Given this list of marker genes MAVS, SRPRB, WASH3P, ANKRD6, ACSL4, VPS13C, ANGPT1, PIK3R1, RBSN, MICALL2, RAC1, RILP, NOS2, CLOCK, CNIH4, ARCN1, TESC, TRMT10B (NCBI Gene Id 158234), IFT122, AP5Z1, LYPLA1, MTX1, EIF4ENIF1, VPS35L, VAMP8, FOXO1 (forkhead box O1), CRH, WHRN, TNF, DENND1B, AP3M1, SH3TC2 (NCBI Gene Id 79628), EI24, VPS45, CAPN10, AP3D1, TRH, TERT, RAMP3, APBA1, TRAM2, SSR3, RHOD, GHRL, CRY2, NUTF2, SCRIB, ACD, SNX33, ACAP1, ZFAND6, SYNE3, MYO18A, ZDHHC9, SYTL5, PAN3, PPM1F, PLCB1, CD74, CD33, MYO5A, SNX14, HAX1, NUP133, NAPA, MTNR1B, ENY2, NECTIN3, RBM4, VPS54, GOLGA7, AP1G1, CHMP2B, RTP1, KCNQ3, JAK2, SYNDIG1, RAB20, MIEF1, MIR130B, HSPA1L, ARL4C, DNM1L, FGF9, XPOT, STXBP3, GORASP1, BBC3, RABEP2, PLEK, LRRC32, COPB1, IL1A, MICALL1, SSR1, NUP153, GOLGA7B, SDAD1, HSPA8, ARL11, IFT56, AP2B1, STX7, SYBU, EPHA5, RAB3B, NUP62CL, HOOK3, STRADB, COG7, DNAJC1, NOMO3, UEVLD, ARL4D, ATP1B1, SIRT7, SCAMP1, CHML, ZDHHC11B, UNC119, WWP2, REP15, PFKL, MAIP1, PPP1R10, PLK3, TUNAR, ADAM9, DUOXA2, SLC1A1, TTN, HOOK1, RANBP17, EXOC6, RBP4, PARD3, CTSD, F2, SRP54 (NCBI Gene Id 6729), ARL8A, ACTN4, NR0B2, AP1S1 (NCBI Gene Id 574017), KDELR1, TOMM34, SNX5, AKAP5, PGAP1, RBM22, PLK1, ELMOD3, RAB21, GIP, IFT27, TMCO6 (NCBI Gene Id 55374), PPARG, STX19, DMAP1, MIR199A1, TMCO1, AP1M1, ZDHHC12, RTP4, SLC7A11, VGF, CCN3, PML, CTAGE15, GRPEL1, TMED3, TOM1L1, UQCC2, PKIA, CACNG3, COPZ1, RAB8A, SQSTM1, BBS1, PLEKHM1, KCNA5, GPIHBP1 (glycosylphosphatidylinositol anchored high density lipoprotein binding protein 1), RAB7B, PORCN, CALM3, TFRC, EIPR1, WBP2, ERBB2, ATG4C (autophagy related 4C cysteine peptidase), RNF31, NASP (NCBI Gene Id 96573), HSPA9, FAF2, HDAC3, WASHC2A, OSBP, CLSTN3, KRT18, NXF1, RPL23, NUP214, C1QTNF5, SNX30, ARF3, PEX16, PSMD9, TOMM20L, SCAMP5, LIN7A, ABAT, IMMP2L (inner mitochondrial membrane peptidase subunit 2), RAB36, FKBP1B, TMEM9, ANO1, WASHC4, XBP1, LAMP1, PRF1, SREBF1, SIRT4, MIR30C1, GET4 (NCBI Gene Id 51608), RANGRF, BMP6, RAB19, RAB1C (NCBI Gene Id 441400), TIMM17B, ARRDC4, VAMP5 (NCBI Gene Id 200553), PDX1, TGFBRAP1, AP5B1, SENP2, HPS6, NPIPA1, ABLIM3 (actin binding LIM protein family member 3), TLK1, ARFGAP3, VPS8, SEC61A1, MIR301B, ZFYVE16, TNPO3, STEAP3, VAMP7, ADORA1, BLK, RAB15, RAB26, APP, HFE, UNC13B, SH3GLB1, PCM1, SEC31A, AP1M2, PHLDB2 (pleckstrin homology like domain family B member 2), HINFP, PKDCC, CALCRL, COMP (cartilage oligomeric matrix protein), MCC, TMEM147, ZW10, ZDHHC6, VPS4A, TSPAN17, CHMP6, SEPTIN8 (NCBI Gene Id 23176), IPO4, STAT3, PEX10 (NCBI Gene Id 5192), TNFAIP3, SNAP23, SCFD2, TFAP2B, PDCD10, MYOM1, TRIM37 (tripartite motif containing 37), PEX7, EDEM2 (NCBI Gene Id 96814), TIMM44, LAMP3, COMMD1, NGFR, ATG4A, SGTA, TIMM23, VPS11, VPS26A, WDPCP, TOMM5, EDNRB, CEP120, KPNB1, NACA, KPNA7, GABARAPL2, ZDHHC7, BAIAP3, COPA, NSG1, NNAT, YIPF5, GSDMD, EXOC3, CMTM6, COLQ, GNPTG, GET3, STXBP2, AAGAB, PEX19, RDX, GOLGA2, GOLT1B, MC4R, LRP2, BAG6, SNX9, SCAMP2, ZDHHC22, WDR11, CEP295, TRPM5, EGFR, ATP13A1, ZDHHC17, TRAK2, ZDHHC15, GCC2, LRWD1, FBXW7, PEX13 (peroxisomal biogenesis factor 13), KDELR3, HSPA4, VAMP3, STX12, LAPTM5, ELMOD1 (NCBI Gene Id 648653), TMEM97, ACVR2B, TAP1, CHMP3, IER3IP1, SLU7, TGFB1, RAPGEF4, ADORA2A, GLE1, SRP9, KPNA5, FMN2, SEC61B (SEC61 translocon subunit beta), B3GLCT, SLC15A4, RABIF, AP1B1, DERL3, SRP14, ADRA2C, CD36, PRKCD, MYRIP, ERC1, NR1D1, VPS36 (vacuolar protein sorting 36 homolog), ABCA12, HRAS, SYTL2, WNK1, GLUD1, SYTL3, ZPR1, SNX31, COPG2, MYO5B, TMEM167A, EMC3, PPP3R1, FFAR1, BTF3, EXOC8 (exocyst complex component 8), LMAN2L, SEC24A, INS, GSK3B, RAB33B, UNC119B, NR1H3, SNX16, PHB2, KPNA2, UBL4A, SCAMP3, XPO1, POM121L2, GRIP2, PLEKHF2, PREPL, RCC2, KCNB1 (potassium voltage-gated channel subfamily B member 1), MVB12B, SGF29, AP3S1, DLG4, TECPR2, RAB27A, WASHC5 (WASH complex subunit 5), HMGCR, MYH10, DOP1B, GGA2, NDUFA13 (NADH:ubiquinone oxidoreductase subunit A13), KIF20A, RAB4A, STX3, NEURL1B, GRPEL2, DYNLT1, NCLN, E2F3, MON1A, TM7SF3, REEP1, ARHGEF2, AP2A1, MED1, LCP1, SYVN1, AKAP3, FAM91A1, BBS5, NMT1, PHAF1, ZFAND1, CLSTN1, CACNG2, ARF4, APPL2, ERBIN, RAB38, AIFM1, C1QTNF3, IPO11, AP2M1 (NCBI Gene Id 1173), GPR119, TOM1L2, VPS39, RUFY3, ANKRD10, PSEN1, AUP1, STX11, CADPS2, SNX6, SYNJ2BP, SNX4, NPLOC4, SYK, BET1L, RAB11B, SYTL4, TIMM17A, PRNP, IFT20, TIMM22, PINK1, USP9X, MIR146A, SNAP91, FFAR2, AKAP6, PTP4A3, TIMM8B, CHCHD4, VPS37D, XPO4, PRKCB, MVB12A, RAB22A, BRSK2, ITGB2, RRBP1, EXOC2, SRPRA, FGB, FRMD4A, CPLX1, FLNA, PICK1, TMED10, IDH2, SNX3, HTRA2, SEC16B, UBL4B, AFG2B, ANK2, GRIP1, NUP88, PRKN, APOD, SNAP29, FHIP1B, CAV1, XPO6, LMTK2, MCOLN1, RAB17, SURF4, TVP23A, LRSAM1, NECAB3, NUP35, SFT2D3, SEC24C, YWHAH, ACHE, GOLPH3, RAB27B, CIB1, WASHC1, GNPTAB, PTPN23, TRAF3IP2, PRICKLE1, DRD2, FRAS1, VMP1, SACM1L, FBXO7, PRKCA, TSNARE1, RHBDD1, ZDHHC3, GZMB, HK1, NDP, UBE2G2, SPIDR, TP53, DUOXA1, SUFU, IFNG, CADPS, CYB5R4, PIN1, USP7, TRIM3, LAMP2, ZBED6, WLS, VTI1B, SCFD1, USH2A, SNX19, ANKRD50, AP3M2, PEX1, STX17, IRS2, TVP23C, KLF7, VPS37B, PHAX, ARFIP1, RN7SL2, MYO1C, MCFD2, NECAP2, MLPH, KIF20B, RAB10, EMC10, ZDHHC20, PCNT, WRAP53, SEC24D, RAB11FIP2, GJD2-DT, CD2AP, SNX1, RALA, SEC23IP, PAK1, ARHGAP44, YIF1B, ASPSCR1, SLC30A8, ZDHHC11, BAD, CHP1 (NCBI Gene Id 11261), FAM3D, SIRT3, ZDHHC14, BNIP3L, SNX7, GRIN3B, IL33, EXOC5, CANX, SP100, RGPD8, YKT6, NBAS, KIF3B, SEH1L, C2CD2L, LEP, CDK16, PEX2, VPS37A, FAM53B, RANGAP1, RANBP3L, RABL3, ATG7, CTAGE8, RPAIN, NR4A1, IMMP1L, RAB37, RFTN1 (raftlin, lipid raft linker 1), SNX27, PDCD6, STXBP5L, IFT22, CBL, JAKMIP1, INSIG1, NUP50, ELAVL1, SORCS2, KPNA6, TMED9, FCHSD2, CDKN2A, MCOLN2, DNAJC19, GCKR, LONP2, ECT2, IPO7, AP1G2, PRAF2, AQP11, EFCAB7, CENPJ, FAM3A, DOP1A (NCBI Gene Id 285787), KPNA4, ARIH2, PIK3R4, SLC15A2 (solute carrier family 15 member 2), RP2, XPO7, GOLPH3L, LCA5, TREM2, CDK1, GPHN, AP3B1, DNM2, RAB23 (RAB23, member RAS oncogene family), ZDHHC21, RAB14, CTCFL, SPG11 (NCBI Gene Id 80208), IRGM, STXBP4, DENND1A, STEEP1 (STING1 ER exit protein 1), KCNJ11, LIMS1, IL12B, POLA2, TCF7L2, ACVR1C, LRP1B, RGPD3, B3GAT3, PIK3R2, BBIP1, MIR19A, RANBP6, TOMM70, TSPO, CYP51A1, CTSA, BHLHE40-AS1, ARL6IP1, RGPD6, SUMO1, FUT11, NSD2, ADCY10, GOLGA4, PIKFYVE, SVIP, GBF1, COPE, ADAMTS9 (NCBI Gene Id 56999), ABCG1, PPIA, POM121C, SEC16A, RAB24, SAR1A, CETN3, HEATR5B, NDFIP2, SPIRE2, EP300, RABGEF1, TOMM7, CTAGE6, RFFL, NUP85, PARL, PTTG1IP, CCDC47, SEL1L, RAF1, CD200, TMED4, TRAM1L1, RASSF9, ABCC8, RAB4B, SPCS2, RGPD1 (NCBI Gene Id 400966), OXA1L, FRAT2, CTTN, MCM3AP, ABRA, VIPAS39, PLEKHA8, KATNB1, AKAP4, ADCYAP1, TOM1, PPT1, OPRM1, ADGRV1, NCF1, SIX2, NAGPA, RIC1, NPEPPS, RFX3, VPS13D, COG8, STX1B, C17orf75, TAOK2 (TAO kinase 2), ATAD1, CSK, MTTP, DPH3, ERGIC3 (NCBI Gene Id 51614), NFKBIA, SLC8B1, IFT25 (NCBI Gene Id 51668), UFM1, CASR, ZG16, CBLB, MIA3, ADTRP, NEUROD1 (neuronal differentiation 1), BCS1L, AP2S1, ARF5, SDCBP, SELENOK, PTPN14, RABL2B, HNF1B, RAB6C, SLC25A22, RAB28, STX18, RAB11FIP3, NUP37, GRIPAP1, JUP, RAB41, EMC1, SNF8, CCDC22, BCAP29, ATP5IF1, GOSR2, LMNA, AP4M1, SRI, DAB2, BLZF1, SNAP25, PRP4K, RAPSN, NDC1, TLR2, RAB25, PER2, C11orf65, SMO, PCID2, GGA3, RAB1B, MPC2, MOAP1 (modulator of apoptosis 1), CLU, PEX3, ERLEC1, SEC24B, KCNN4, SEC23B, SMAD2, SERGEF, GJA5, KIF18A, PLA2G1B, ARL3, CPT1A, ILDR2, AKT1, RAB3D, TIMM9, PRKD1, TNPO2, PARD6A, TIMM8A, TVP23B, VPS26C, CPLX3, MTX2, NETO1, NXT1, CCL5, LRRC7, H1-5, ZFAND2A, IL1RN, MACF1, SLC15A3 (NCBI Gene Id 51296), MAPK14, EMC4, DNAJC27, RAB9B, SNX25, CD38, MTCL1, ATG16L2, PEX5, ATP13A2 (ATPase cation transporting 13A2), MAN1A1, ZDHHC4, BAP1, DNAJC15, TTC9-DT, SLC4A8, PPP3CA, PTPRN2, ZNF827, PCSK5, TERF1, PEX26, TM9SF4, ADAR, RILPL1, BSG, ARF6, GNAO1, ERP29, MLC1, KCNE1, RAB12, SPDYA, AFDN, MVP, UBAP1, FYN, TTC8, PCK2, MTERF4, MAL, CHMP4B, DNLZ, WASHC2C, RAB18, TAP2, APBA3, HOMER3, CD3G, TANGO2, HERPUD1, NR1H4, ADRA2A, IPO5, DENND2A (DENN domain containing 2A), CLN3, RIMS2, RAP2A, GIPC1, RPGR, NLGN1, PEX5L, VPS26B, AIP, SNX13, STX1A, MFF, EMD, IPO13, GLI3, NUP155, RAB5C, LRP5, RAB3GAP1, AP1S2, DERL1, TRAM1, APOBEC1, BCR, HOOK2, RAB11A, CHMP7, REEP2, MAPT, SNX8, ZDHHC1, MIR29B1, OAZ1, LIN7C, AP1S3, CNST, GABARAP, VPS35, SNX11, ARFGAP2, GIPR, RAB39A, OAZ3, RAB5IF, RGPD2, SSTR5, NEURL3, ARF1, USE1, SIRT6, STRADA, PRKAA1, NUP205, TBC1D13, KPNA1, SEC22C (SEC22 homolog C, vesicle trafficking protein), VPS41, HLA-DRB1, NAPG, ICMT, EDNRA, STAM, GNAZ, PPP3CB, MYO7A, COG6, UBE2D3, NUP62, MTX3, RAC2, GCG, MIR93, GOLT1A, XPO5, FRMPD1, GDI2, COPB2 (NCBI Gene Id 9276), APOE, COG2 (component of oligomeric golgi complex 2), GBP5, ITPR1 (NCBI Gene Id 619543), JAGN1 (NCBI Gene Id 84522), LEPROT, CD24, IL6, RIMS1, AP2A2, USP36, PGRMC1, AFM, COPG1, COG1 (component of oligomeric golgi complex 1), HK2, ANKLE1, SSR2, BAX, RN7SL3, NPAP1, SLC7A6OS, STX2, TRIM23, GSK3A, TMED6, NUP188, BBS9, LMAN2, BMP8A, P2RX7, ARL6, IRS1, AAAS, CBLN1, TENM1, LMAN1 (NCBI Gene Id 3998), GHSR, SCG2, PTPRN, RAB11FIP1, MYH9, DDIT3, ENTR1, MIEF2, RAB29, TMEM129, STK4, LSG1, HSPB1, RD3, SNAP25-AS1, CNTN2, RAB5A, UNC93B1, CLTC, INPP5K, ROMO1, LARGE1, PDE8B (phosphodiesterase 8B), PDCD6IP, USO1, DNAJC14, HIKESHI, CORO2B, BAG4, DRD1, SFN, ICE1, ATG14, ITGB1BP1 (NCBI Gene Id 9270), OS9, SLC12A2, TLR4, PTPN1, MCL1, NECAP1, APPBP2, TIMM21, F2RL1, HUWE1, TXN, EPB41L5, DMTN, TMED2, ZFAND2B, PARK7 (Parkinsonism associated deglycase), PRKCE, EMC9, ATG16L1 (autophagy related 16 like 1), MX2, AP4S1, RIPOR1, CALR, SYNGR1, SUCNR1, RABEP1, USP17L2, CENPF, GGA1, B4GALNT2, SOX4, B2M, F2R, CDKN1A, DENND4C, MAFA, LYST (lysosomal trafficking regulator), C1QTNF12, UBE2L3, HSPD1, PHPT1, MGARP, TIMM50, FIS1, NF1, SIDT2, KIF5A, PRKAR1A, RAB3IL1, CHRM3, CEP135, UMOD, NUP93, GNAI1, AKAP8, KIF5B, SCG5, P3H1 (prolyl 3-hydroxylase 1), TNPO1, SLC51B, CEMIP, GPLD1, SGTB, RAB31, RTP3, MCU, VPS50, ARL8B, LYPLAL1, RAB43 (RAB43, member RAS oncogene family), PIM3, RAB9A, FAM53A, AHCYL1, ATG13, ALOX5, ZIC1 (NCBI Gene Id 7545), ARRDC5, SNX21, GAL, GCK, MON1B, MACROH2A1, RAP1GDS1, CTDSPL2, ABCB9, FKRP, GPR27, CTAGE4, BBS7, PCLO (NCBI Gene Id 56630), ASTN2, NPC1, WDR83OS, RAB8B, STX8, RHBDF1, PITPNM1, POM121B, MIR148A, PTPN11, ARL5A, IPO9 (importin 9), VPS13A, PPY, NR1H2, RANBP2, TMEM126A, APBB3, EMC2, RAMP1, VPS53, SMURF1, CHRM1 (cholinergic receptor muscarinic 1), RACK1, FUT10, UBE2Q1, HERC2, CFTR, ARRDC1, YOD1, SORL1, EHBP1, ATG3, DNAJC13, ATP6AP1, SEC61G, NUP98, VPS37C, CEP290, VAMP2, RN7SL1, SNAPIN, HEATR3, HSP90AA1, PLEKHA1, PFKM, RABL2A, SCAMP4, HCAR2, MTM1, SNUPN, RAB3GAP2, TACR2, TREX1, EXPH5, FAM53C, RFX6, SNX24, HNF1A, MAPK8, SERP1, TIMM13, RTN2, MIR128-1, CAMSAP3, NLGN2, TBC1D17, NIPBL, RAB13, LIN7B, NUP210, GPM6B, VPS16, DTX3L, AFTPH, DZIP1, PREB, MYO1D, SLC9B2, KCNK16, ZDHHC24, RPH3A, MYO6, CABP1, ZDHHC23, KCNJ8, BBS2, RAPGEF3, NACAD, CARTPT, VIP, MAPK8IP3, YWHAZ, GDI1, PEX14, TMED1, DGKD, VPS18, AGAP2, DENND10, ARFIP2, HSPA5, APBA2, BCAP31, COG3, ADAM8, RAB34, PRR5L, SNCG (NCBI Gene Id 6623), UCN3, IST1, HACL1, RAB6B, CWH43, EMC7, SLC35D3, TPR, CLIP3, RUVBL2, ANXA13, TCAF1, VPS28, LRRC8A, MFN2, DYNLL1, BCL3, NRARP, ARHGAP1, RAB5B, GPR89B, KIF14, NUP43, SNX18, FZD5, UCP2, RHOU, TRPM4, RAB3A, IPO8, AHCTF1, STAM2, TIMM29, EXOC6B, NCOA4, STK3, CCDC91, TCAF2, CTAGE9, KRT20, EXOC4, EDEM1, RAB35, RHBDD3, GFER, SPTBN1, CPLANE2, SYS1, UBR5, ATP2C1, MACIR, RAB3IP, AGAP1, KLHL20, CHMP2A, COG5, EPM2A, ARL17B, SIL1, G6PC2, OOEP, ARFGAP1, UBE2J2, HGS, SLC2A2 (solute carrier family 2 member 2), CEP131, SNX15, GPER1, SPIRE1, ADCY8, ARL5B, BID, VEGFC, TOMM40L, CTAGE1, REST, TGFB2, ARRDC2, NSF, LAMP5, ANKRD27, SEC61A2, CDC37 (cell division cycle 37, HSP90 cochaperone), BRAF, SEC63, BECN1, RINL, SAA1, RHOB, SEC23A, GLP1R, CLTRN, HIF1A, GDAP1, TOMM40, AKIRIN2, MAMDC4, ARL4A, BICD2, HYAL2, HM13, ITSN1, RGPD4, C2CD5, ENSG00000283175, GFAP, TIMM10B, CHGA, RAB6D, ATG4D (autophagy related 4D cysteine peptidase), ISL1, DTNBP1, PRKCI, NEDD4, HIP1, ELFN1, TSPAN10, CAMK1, RAB7A, HNF4A, ATG4B, CCHCR1, TRIP11, SAR1B, COMT, PARP11, HSP90B1, PIK3C3 (NCBI Gene Id 5289), BLOC1S6, OAZ2, CHM, CCDC186, CBLN4, RTP5, ATF2, UHMK1, RSC1A1, BLOC1S3, SNX2, ARL14, CDK5, EIF2D, UBAC2, VTI1A, VLDLR, NDUFAF2, LTBP2, EXOC1, SNX32, TRARG1, ABCA1, UBL5, OXCT1 (3-oxoacid CoA-transferase 1), TXNIP, APBB1, COPZ2, OPTN, NDEL1, KIAA0586, PMPCA, CD81, PFKFB2, COX18, CORO7, UBE2J1, F2RL2, IL1B, KIF3A, GOSR1, TIMM23B, VPS4B, SEC13, CEP41, FGA, PDZK1, ANKRD13C, TANGO6, BMAL1, HPCA, AZGP1, ADCY5, ARL6IP5, SPAG17, GAPVD1, RAB39B, AP4E1, ARRDC3, HPSE, NMD3, SELENBP1, PPARD, FOXA2, IGF1, DAG1, ORAI1, PAFAH1B1, POT1, VAMP4, SELENOS, MAP1LC3C, TIMM10, TOMM6, CHMP4A, MIA2, RSAD2, FERMT1, PPM1A, STXBP1, STX5, ARFGEF2, GUK1, DESI1, LRRK2, ENSA, SNX12, PAM16 (NCBI Gene Id 51025), ZDHHC18, EHD3 (EH domain containing 3), ARL5C, CTNS, TMED5, PLA2G6, TRPA1, RCN3, VPS33B (VPS33B late endosome and lysosome associated), GOPC, RILPL2, APPL1, CHMP1A, TMEM30A, SYT4, SMYD3, SVBP (NCBI Gene Id 374969), RHBDF2 (rhomboid 5 homolog 2), STX6, ARL1, NEO1, TCIRG1, SELENOT, ANKRD1, ARRB2, M6PR, CELA2A, ING1, AKTIP, SCARB2, ATG10, ADAM11, PEX6, NADK, PPID, NOMO2, NPNT, TMEM132A, EMC6, ANK3 (ankyrin 3), KPNA3, PRKACA, STX4, NDFIP1, LTBP1, TUBA1A, BET1, CAMK2G, CHMP1B, VPS51, ASPH, HAP1, CRYZL2P-SEC16B, SNX22, RAB6A, ZC3H12A, PDZD7, DERL2, TMED7, NKX6-1, AP5M1, BAG3, TFR2, RAB32 (NCBI Gene Id 10981), INHBB, KIF5C, RGPD5, STXBP5, VPS52, SRP68, MACROH2A2, MMP12, MDFIC, S100A13, CORO1C, FGG, RAB11FIP5 (RAB11 family interacting protein 5), ACSL3, FRAT1, NUP107, YIF1A, CD63, VPS25, SMAD3, RAB3C, MIR199B, KDELR2 (NCBI Gene Id 11014), SIX3, MON2, SFT2D1, NACA4P (NCBI Gene Id 83955), DRD4, SAE1, VCP, NUP160, ARFRP1, SYNRG, TRAK1, KIF13A, HADH, MTCH1, RPH3AL, TBC1D5, MTCH2, CLTB, SRP19 (NCBI Gene Id 6728), SYTL1, UFD1, BMP4, NUP42, DMBT1, RTP2, CHMP5, MAP1A, VTA1, RINT1 (RAD50 interactor 1), ANP32B, DLG2, RPL11, CHP2, SAMM50, YWHAB, ADIPOQ, TNKS, NAPB, TSC2, RAB2A, STOM, TARDBP, ARRB1, CDH1, EGR2, SFT2D2, APOB, NPFF, CHMP4C, GNA11, TSG101, YWHAG, DOC2B, CFL1, PMPCB, AP3B2, BRCA2, IL10RA, KIF17, HDAC6 (histone deacetylase 6), GORASP2, PEX12, ZDHHC2, CCT6A, VPS33A, RAN, IFIT1, VSNL1, PKIG, MMGT1, ANG, SNX17, PKD1, SPRN (NCBI Gene Id 503542), NRXN1, AKT2, GNAS, EXOC7, MIPEP, TCP1, SNX10, IFI27, TMEM30B, CCDC85C, CCDC93, GPR68, MIDN, SLC15A5, VPS29, ITGA8, RANBP3, NOMO1, AGK, RAB2B, YWHAQ, GET1, EPS15, NUP54, CLTCL1, RAMP2, AP5S1, FAM3B, SEC22A, SREBF2, CAVIN1, SEC62, NXT2, HPS4, SHH (NCBI Gene Id 6469), IL12A, EFNA5, CD68, RUFY1, NACA2 (nascent polypeptide associated complex subunit alpha 2), CSNK2A2 (casein kinase 2 alpha 2), BARD1, ARHGEF5, CETN2, MIR766, TRIM28, NOTCH1, STX10, RYR2, SORT1, OR51E2, RABGAP1L, KIF13B, OLFM2, EMC8, MIR19B1, TOMM20 (translocase of outer mitochondrial membrane 20), AACS, YWHAE, LRP1, CUBN, COL1A1, SLC15A1, TMEM115, WASHC3, ZDHHC19, MBTPS1, CEP55, CAMLG, SPCS1, GAS6, SLC16A1, ARFGEF1, MDM2 (MDM2 proto-oncogene), AMN (NCBI Gene Id 81693), CDK5R1, ELFN2, PDIA4, DNAJA1, NMU, HCLS1, SPCS3, FUZ, NPM1, AP4B1, ZMAT3, LMF1, IL13, NUP58, GPRC6A, RAB1A, STX16, EHD1, MSR1, TGFB3, ARHGAP33, KTN1, SEC31B, TOMM22, FAM76B, SEC22B, SNX20, COG4, POM121, NABP2, BBS4, AP3S2, DRD3, ITGAM, SIAH3, PITRM1, SRP72, AP1AR, GPR89A (NCBI Gene Id 653519), CSE1L, CLTA, SYT7, MLXIPL, here is a description of the gene set: The directed movement of a protein to a specific location. studied in species Homo sapiens Human Gene Set: GOBP_ESTABLISHMENT_OF_PROTEIN_LOCALIZATION